The following is a description of a gene set: Mouse Gene Set: GOBP_NEGATIVE_REGULATION_OF_MICROTUBULE_POLYMERIZATION Any process that stops, prevents, or reduces the frequency, rate or extent of microtubule polymerization. species: Mus musculus, and this is the list of marker genes: Eml2, Tubb4a, Tbcd, Fkbp4 (FK506 binding protein 4), Arhgef7, Stmn2, Inpp5j, Snca, Map2 (NCBI Gene Id 17756), Sgk1, Mapre1, Cdh5, Stmn1, Clip3, Dyrk1a